Given this list of marker genes TBC1D23, MARCHF7, TARS1, KHDC4, COPS6 (COP9 signalosome subunit 6), LUC7L2, ARID1A, ACTR10, PPIL4 (peptidylprolyl isomerase like 4), CHTOP (chromatin target of PRMT1), RAB9A, JKAMP, DHX36, PCNP (NCBI Gene Id 57092), MKRN1, RPL7L1, C1orf43, MRPL45, RANBP9, LAMTOR3, ZNF212, TCERG1, USP47, MAP3K2, OLA1, CUL5 (NCBI Gene Id 8065, cullin 5), RNASEK, ZNF644, RBM25, FOXJ3, PIP4P1 (NCBI Gene Id 90809), MFSD14A, PCF11 (NCBI Gene Id 51585), SNRNP200, USPL1, EAPP, IRF2BP2, COMMD9, SLAIN2, NAA30, HBP1 (NCBI Gene Id 26959), ZBTB33, SF3B4, ZCCHC8, MED17, GTPBP1, HECTD1, HNRNPR, TARDBP, BTF3L4, FNBP4, PRPF8, KLHDC2, HNRNPH3, YTHDF3, MTDH, ZFAND5, KANSL3 (NCBI Gene Id 55683), TAB2, PPM1B, RRN3, PHACTR4, SCAF8, SAP130, C1orf52, ARID4B, PRKRA, ZC3H14, COPS2, SENP7 (SUMO specific peptidase 7), here is a description of the gene set: Neighborhood of HBP1 Neighborhood of HBP1 HMG-box transcription factor 1 in the GCM expression compendium Human Gene Set: GCM_HBP1 species: Homo sapiens